The following is a description of a gene set: Human Gene Set: GOBP_POSTSYNAPTIC_MODULATION_OF_CHEMICAL_SYNAPTIC_TRANSMISSION species: Homo sapiens Any process, acting in the postsynapse that results in modulation of chemical synaptic transmission., and this is the list of marker genes: GHRL, GRM3, CLMP, NEFL, EIF4E, RASGRF2, TRIO, CDH1, CYFIP1, WNT5A, SLC1A1, INA, DCC, USP8, GHSR, NEFH, PRKACA, GNAO1, PPP3CA, SNX14, ATG5, MDM2, BRAF, PPP3R1, FBXO2, CHRM1, NRGN, DRD2, SORCS3, PLCB1, EIF4A3, IGF1